The following is a description of a gene set: from publication Shipp MA, Ross KN, Tamayo P, Weng AP, Kutok JL, Aguiar RC, Gaasenbeek M, Angelo M, Reich M, Pinkus GS, Ray TS, Koval MA, Last KW, Norton A, Lister TA, Mesirov J, Neuberg DS, Lander ES, Aster JC, Golub TR (PMID 11786909) Human Gene Set: SHIPP_DLBCL_VS_FOLLICULAR_LYMPHOMA_UP studied in species Homo sapiens Top 50 up-regulated markers distinguishing diffuse large B-cell lymphoma (DLBCL) from follicular lymphoma (FL) samples. Diffuse large B-cell lymphoma (DLBCL), the most common lymphoid malignancy in adults, is curable in less than 50% of patients. Prognostic models based on pre-treatment characteristics, such as the International Prognostic Index (IPI), are currently used to predict outcome in DLBCL. However, clinical outcome models identify neither the molecular basis of clinical heterogeneity, nor specific therapeutic targets. We analyzed the expression of genes in diagnostic tumor specimens from DLBCL patients who received cyclophosphamide, adriamycin, vincristine and prednisone (CHOP)-based chemotherapy, and applied a supervised learning prediction method to identify cured versus fatal or refractory disease. The algorithm classified two categories of patients with very different five-year overall survival rates (70% versus 12%). The model also effectively delineated patients within specific IPI risk categories who were likely to be cured or to die of their disease. Genes implicated in DLBCL outcome included some that regulate responses to B-cell-receptor signaling, critical serine/threonine phosphorylation pathways and apoptosis. Our data indicate that supervised learning classification techniques can predict outcome in DLBCL and identify rational targets for intervention., and this is the list of marker genes: DLGAP5, MIF, PLOD1, CCNB1, P4HB, CCT5, LGALS3, CLTA, MCM7, IDH2 (isocitrate dehydrogenase (NADP(+)) 2), KPNA2, HSP90AB1, ATIC, PSME2, CENPA, CCT3, PSMC1, NME1, CTSD, HSPD1, HCK, THOP1, LDHA, SNRPB, PKM, MTHFD2, SLC1A5, PFKP (phosphofructokinase, platelet), EXOSC7, BCL2A1, CDKN3, TRAP1, TFRC, HSP90AA1, MELK, IFI30, IMPDH2, PGAM1, GM2A, ENO1, SLC29A1, ALDOA, SAT1, PRDX1, HMGA1